Given this list of marker genes Kdm4b, Fibin, Tvp23b, Psg16, Pcdhgb2, Rc3h2, Otol1, Rnf152, Amn1, Tmem199, B3gnt5, Bicd1, Eif3a, Tox4 (NCBI Gene Id 98198), Fgf16, Spdl1, Lrig1, Brox, Gmfb, Lrrc7, Yeats2, Akap11, Zfx, Anp32e, Smim7, AI593442, Efnb2, Synj1, Il15ra (NCBI Gene Id 98822), Eea1, Zcchc24, Ttc7b, Arhgap11a, Mindy2, Rab3ip, Speg, Adcyap1, Thap1, Boc, Nek7, Mfsd1 (major facilitator superfamily domain containing 1), Map3k12, Zfp367, Pan3, Glrb, Atxn7, Pin1, Nlgn1, Zfp800, Tbp, Clca4a, Wnt9b, Tsc22d2, Thsd7b, Phyhipl, Kcnh8, Fam177a2, Nckap5, Sv2a, Il17a, Ewsr1, Dnd1, Csf3, Hsd17b7, Nr1h4, Zfp839, Bmp5, Tmem169, Serinc5, Pcgf3, Dnajc6, Cmtm4, Uba2, E2f1, Ncs1, Hectd2, Homez, Whrn, Cldn14, Gtf2e2, Dip2b, Cops2, Aqp5, Vezt, Kntc1, Casd1, Notch3, Neurod1, Zc3h15, Birc5, Hyou1, Zdhhc21, Cx3cl1, Asxl1, Lrch1, Fzd8, Rgs16, Dlat, Pcdhga6, Ppp3r1, Shox2, Ofd1, Itga6, Il12a, Jmy, Lysmd1, Map2k6, Hoxa3, Slc35a3, Lrfn4, Anln, Sema3a, Neurog2, Palld, Rnf111, Phf21a, Zc2hc1a, Ranbp9, Olfm3, Dusp8, Fam89a, Slc35d1, Atad2b, Map2k1 (NCBI Gene Id 26395), Srm, Lamc1, Selenoi, Celf4, Stk40, Tnfsf9, Med1, Prpf40b, Ptpdc1, Spry2, Rictor, Peli2, Ccbe1, Aldh1a3, Icam1, Med13, Galnt18, Cacna2d1, Pmaip1, Gng12, Adamts1, Dnaaf9, Actr10, Dpf3, Thbd, Ch25h, Mmaa, Cnot6l, Lrat, Cask, Adgrl4, Mier3, Foxp1, Tns3, Adamts19 (ADAM metallopeptidase with thrombospondin type 1 motif 19), Ccn1, Aff4, Cep120, Gpr158, Cdc42bpg, Cftr, Tubgcp5 (tubulin, gamma complex component 5), Carmil1, Ffar4, Pdik1l, Sycp2, Bicral, Pcdhga7, Daam1 (dishevelled associated activator of morphogenesis 1), Smurf2, Card19, Mafk, Arid5b, Clk3, Bdnf, N4bp2l1, Ppp3cc (protein phosphatase 3, catalytic subunit, gamma isoform, NCBI Gene Id 19057), Radil, Dock4, Nedd1, Tiam1, Katnal2, Btbd10, Trp53inp1, Fam91a1, Ddx3x, Tmem33, Btbd8, Uimc1, Retreg1, Dap3, Spryd7, Rgs20, Tet2, Brinp2 (NCBI Gene Id 240843), Limch1, Atxn2l, Ccdc82, Akap12, Sprr2a2, Wnt5a, Rab6a, Kcng3, Tyr, Stk3 (NCBI Gene Id 80435), Hif1a, Lin9, Irx2, Dpp4 (NCBI Gene Id 13482, dipeptidylpeptidase 4), Notch1, Abcg4, Mzt1, Il4, Gpatch2l, Nr1d1, Plk3, Zfp950, Baz1a, Amer3, Hoxd8, Ptchd4, Gng2, Tppp, Htr4, Cd274, Csgalnact2, Rala, Clcn3, Pif1, Zfp292, 1700066M21Rik, Hk2 (hexokinase 2), Gpc2, Myef2, Tfap2e, Elavl1, Lrrc39, Pcdh11x, Tmeff1, Dspp, Tmem132c, Baz2a, Dlg2, Stk26, Frk, Plk2, Cytip, Macroh2a2, Fa2h, Arl5a, Usp31, Dynll1, Pnisr, Prkce, Tesk2, Syt14, Lrrc71, Tmprss11g, Pcdhgc3 (protocadherin gamma subfamily C, 3), Baz1b, Slmap, Nphp3, Dmtf1, Chmp5, Inppl1, Twist2, Rbpj, Mmgt1, Id2, Fasn, Idh2, Lats1, Trpc1, Traf4, Tspan14, Onecut2, Bmp4, Bdp1, Golt1b (NCBI Gene Id 66964), Edn2, E130308A19Rik, Trak1, Shroom3, Nfxl1, Celsr2, Rgs17, Cep85, Ppfia2, Gad1, Dctn6, Pcdhga2, Hnrnpll, Kcnb2, Atosa, Elavl4, Nlrc5, Dock5, Trappc13, Kcnma1, Bloc1s4, Grpel2, Pof1b, Fat1, Odf2, Tmem68, Rora, D3Ertd751e, Lmtk2, Sass6, Myrip, Rap2c, Efs, Zic2, Cnot2, Jade1, Tmem161b, Hrh1, Tmem167, Irag1, Tnfrsf22, Epha7, Prss56, Mcur1, Eif4a2, Foxj3, Fam135a, St18, Zfp979, Pcdhgb8, Pcdh18, Samsn1, Col5a2, Nppb, Cadm2 (NCBI Gene Id 72986), Clasp1, Il1r1, Etnk1, Zfyve27 (NCBI Gene Id 72352), Scn1a, Zfp941, Rab3a (RAB3A, member RAS oncogene family), Dlg4, Ube2ql1, Zxdc, Macf1, Lrp6, Aftph, Csrnp2, B230219D22Rik, Ehbp1, Bbx, Tox3, Gdf15, Serpini1, Zxdb, Epc2, Mtm1, Robo2, Pknox2, Wdr47, St8sia2, Gm13889, Mmp16, Gfod1, Col8a1, Axin2, Cdk17, Tmco3, Tmem67, Skor1 (NCBI Gene Id 207667), Zcchc9, Csf2 (NCBI Gene Id 12981), Eif2ak3, Pecam1, St8sia5, Tusc3, Rasgrf2 (NCBI Gene Id 70739), Ube2w, Gfpt2, Bod1l, A830018L16Rik, Hps3, Atp6v1c1, Adamts4, Sntb2, Cdh9, Rnf182, Plat, Nr1d2, Zbtb24, Ebf1, Irak2, Arhgef9, Kif14, Emc1, Pip4p2, Wnt3, Cul5, Ciao1, Rph3al, Adgrb3, Eya3, Srpra, Rfx6, Matn3, Rab40c, Zfp365 (NCBI Gene Id 674611), Stard13 (NCBI Gene Id 243362), Asap1, Dda1, Ankrd44, Stambpl1, Dmd, Zfp758, Zfp667, Slc6a1, Wdr26, Pbrm1, Hcn3, Lrrk2, Ldlr, Phip, Zfp790, Phtf2, Tshz1, Slc4a7, Cyp7a1, Mfsd6, Tmem196, Kcna1, Csrnp1, Hhip, Taf3, Chrd, Lrsam1, Nr5a2, Abr, C1galt1, Ptar1, Kctd6, Asah2 (NCBI Gene Id 54447), Plekha1, Prdm6, Zfp236, Nr4a3, Gem, Lmo7, Fstl3, Hectd4, Nrn1l, Aldh1a2, Vegfa, Pcdha4b, Neurod4, Lcp2, Ccp110, Heatr5b, Slc16a12, Tti1, Igfbp3, Zfp503, Foxf1, Usp46, Gpr174 (G protein-coupled receptor 174), Pcnx1, Ppat (NCBI Gene Id 97242), Tsga10, Atxn7l3, Fzd1, Celsr1, Adamts6, Crhr1, Sin3b, Vps37a, Spring1, Map1a, Fign, Sh3glb1, Usp12 (ubiquitin specific peptidase 12), Ppm1h, Slc45a3, Baz2b, Cdyl2, Cxcl1, Zbtb10, Vbp1, 1810055G02Rik, Snai1, Myl12b (NCBI Gene Id 98057), Ntf3, Rnf225, Snrnp27, Tnfaip3, Prr12, Adamts9, Zc3h12c, Grk3, Cdk6, Sprr2a1, Hivep1, Adamtsl1, Fgf4, Wnt11, Glce, Ssxb10, Mast4, Arhgef26, Dnal4, Zfp609, Thsd7a, Ccl20, Phox2b, Tbc1d9, Agfg2, P2ry1, Ncoa7, Ngf, Gapvd1, Yae1d1, Pfkm, Brsk1, Dennd4b, Cfap69, Smarcad1, Plekhm3, Edn1, Rbm27 (RNA binding motif protein 27), Il22, Fpgt, Cflar, Serinc1, Nlrp3, Crim1, Gtf2a2, Pex13, App, Lin7a, Rnf214, Got1, Gsc, Zswim6, Psmc3ip, Rrm2b, Pgbd1, Lpl (NCBI Gene Id 16956), Rccd1, Stag1, Sytl4, B4galt6, Gba2, E2f2, Ntrk3, Ino80d, Usp15, Fam221a, Nup155, Map9, Rasef, Ttbk2, Atosb, Bcor, Angpt1, Adamts16 (NCBI Gene Id 328284), Zfp143, Pias2, Rif1, Six1, Elmod2, Ccar1, Fgf10, Ppp2r5e, Rwdd3, Pik3c2a, Pik3cb, Cd28, Lep, Drd1, Cdca4, Asb7, Pou3f1, Slc25a14, Pate2, Ark2n, Megf6, Tm9sf3, Klhl2, Bcl2, Il31, Agfg1, 2310057M21Rik, Unkl, Il5, Slc5a12, Ipcef1, Trim33, Epas1, Elavl3 (NCBI Gene Id 66572), Pcdhgb1, Chfr, Herc1, Ssr3, Lrp8, Rufy2, Tet3, Plxnb3, Sall3, Gpr65, Tfap2a, Bnip5, Rnf145, Cdh8, Nup188, Noa1, Gdnf, Gtf2a1, 4921524J17Rik, Cnst, Trp53bp2, Opa1, Slc16a10, Zfp804a, Tcf12, Tubgcp3, Cd200, Kcnc2, Mphosph6, Fgf9, Sinhcaf, Smad7, Atp6v1e1, Fosl2, Pigf, Edil3, Rbbp8, Nup160, Lyrm9, Camta1, Cdkl3, Fzd7, Spag9, Pgf, Orc1, Cux2, Clmn, Tnfrsf11b, Elavl2, Elovl3, Pi15, Gsx1, Csn2, Papola, Atp2a2, Gria4, Mbnl2, Chst11 (NCBI Gene Id 68647), Abhd10, Bhlhe23, Sgk3, Eif5, Rybp, Gabra2, Arf4, Micall1, Pcdhgc5, Capn7, Dek, Il13, Shisa3, Ahr, Trio, Smg8, Arhgef2, Prkch, Cpa4, Pfkfb2, Rnd3 (NCBI Gene Id 99050), Pla2g4e, Actmap, Adap1, Akap13, Cish, Usf3, Rims2 (NCBI Gene Id 72660), Efemp1, Arih1, Ptch2, Nhlh2, Slc25a22, Heca, Kdm2b, Znrf3, Klhl18, Rngtt, Rmnd5a, Mkrn3, Mef2a, Ssxb9, Nt5c3 (5'-nucleotidase, cytosolic III), Hoxc4, Il3, Spry4, Cers2, Vax1, Kiss1r, Foxq1, Trappc8, Zfp689, Bpnt2, Carf, Insc, Abi3bp, Ncapd3, Erp44, Ptprm, Golim4, Arhgap42, 5730507C01Rik, Fam228b, Jhy, Nfe2l2, Simc1, Epha4, Tbc1d23, Fam3c, Eif2b3, Myt1l, Trip4, Arhgef3, Pabpc5, Med12, Il21, Smim17, Rbms1, Myl12a, Unc80, Fndc3b (NCBI Gene Id 99920), Ambn, Sertad4, Fam204a, Naa15, AU015228, Gpr171, Fzd4, Sgo2a, Pcdhga9, Fut9, Zfp592, Nhlh1, Kif5b, Adamts20, Acsl4, Tmem88b, Lhx3, Mgat4c, Col9a1, Malt1, Fgr, Zmym2, Nbea, Rock2 (Rho-associated coiled-coil containing protein kinase 2), Efhd1, Ssbp2, Lin54, Rasgrp1, Zbtb26, Yju2b, Tbx5, Vasn, Tiparp, E2f8, Lipg, Cpeb3, Slc37a1, Tnfaip6, Tnfrsf10b, Ndufs4, Baalc, Cycs, Sstr1, Atrx, 1600014C10Rik, Gtf2f2, Stxbp1, Socs3, Rnf139, Nog, Hagh, Ptx3, Pdp1, Slit2, Six4, Mcc, Satb2, Macir, Rad17, Foxn4, Smad6, Pdzd8, Neurl1a, Ssxb2, Gnai1, Itgav, B3galnt2, Hoxb9, Reps2, Ankrd13d, Csmd3, Calm1 (calmodulin 1), Wnt9a, Mtfmt, Jazf1, Mfap3l (microfibrillar-associated protein 3-like), Plce1, Traf5, Mmp13, Zbed6, Dgkd, Nsun6, Ifnb1, Myt1 (NCBI Gene Id 18237), Ptp4a1 (NCBI Gene Id 98792), Mrpl41, Ccdc50, Foxn2, Hamp, Cntn3, Slc38a2, B3galt1, Dll3 (delta like canonical Notch ligand 3), Fos, Fgf21, Auh, Fancm, Prickle1, Col11a1, Fmr1, Tecrl, Skint7, Mrpl1, Cggbp1, Zfp516, Mblac2, Ror2, Rnf43, Bcr (NCBI Gene Id 71258), Ric1, Tmtc1, Zfp963, Mllt3, Dusp11, Neto1, Car8, Gpd2, Ficd, Cass4, Bmpr1b, Klf11, Ncor1, Tra2a, Skil, Slc2a3, Nufip2, Fgfrl1, Atp6v0c, Slc12a7, Pcdhga8, Ube3a, Efcab7, Fyttd1, Ifi213 (NCBI Gene Id 623121), Fam78b, Arl6ip6, Atg16l1, Cdkn2aipnl, Atp13a3, Cmas, Zfp329, Bmp7, Or7d10, Kcnh1 (NCBI Gene Id 16510), Tlcd4, Pdcl, Arpp19, Mtpn, Zfp830, Ppp2r5b (protein phosphatase 2, regulatory subunit B', beta), Hunk, Eloa, Pax9, Tmtc3, Tmem52b, Tulp3, Mesp1, Stk39, Nploc4, Atp10a, Mcfd2, Srprb, Dusp1, Suz12, Snip1 (NCBI Gene Id 76793), Ap4e1, Fzd3 (NCBI Gene Id 320969), Lrp12, Cbx4, Sft2d2, Cstf3, Rgma (repulsive guidance molecule family member A), Dlgap2, Ankrd12, Pcdhga12, Slc30a9, Tnf, Ermn, Actc1, Snapc3, Kcnk1, Tlcd3b, Osbpl8, Tinagl1, Micu3, Nabp1, Nr6a1, Inpp5a, Fgf15, Cdh10, Gm38666, Pde3b, Zfta, Osm, Ikzf2, Kctd9, Hapln1, Nxpe3, Gbx2, Jkamp, Prkaa2, Chac1, Yipf4, Tanc2, Lrig3, Hmgb2, Atg4d, Zeb1, Sorcs1, Cox17, Tmem185a, Nkd1, Tbx20, Hs6st1, Piezo1, Psd3, Zfp9, Ube2v2, Arhgap29, Col12a1, Gfpt1, Zbtb49, Dlc1, Nrarp, Ptk2, Camsap1, Mideas, Tshz3, Rp1, Bcl11a, Ccdc171, Trp53rkb, Slc35d3, Col2a1, Pcdh20, Doc2b, Cttnbp2nl, Mfsd14b, Arhgef10, Zfp11, Ubxn7, Myo10, Ostf1, Tceal1, Pcdhgb5, Tdrd3 (tudor domain containing 3), Wls, Paxbp1, Srebf1, Adam22, Tbc1d15, Grb10, Ndufv2, Rapgef4, Efr3b, Yod1, Syt4, Acvr1, Ddr2, Cobll1, Strbp, Arpp21, Stim1, Enc1, Cnot6, Pdxp, Akap6, Il11, Sox6, Dcaf12, Ptpn13, Cyld, Lrch4, Elk1, Cldnd1, Bcl7a, Lrrc4c, Lif, Spopl, Tlr3, Fgf20 (NCBI Gene Id 80857), Ark2c, Ssxb1, Pcdhgb4, Ikzf5, Scoc, Pdlim5, Hsf5, Rab18, Kmt5b, Arhgap6, Pcbp2, Lgi1, Clcf1, Zdhhc9, Mak16, Myo1b, Mapre3, Rbm24, Tmcc2, Peli1, Cldn23, Nadk2, Rarg, Pum2, Plau, Dner, Nufip1, Samd4, Clip4, Abcb1a, Cd300lf, Kansl1, Mindy3, Fzd5, Wnt7a, Cds2, Cpeb2, Bmpr2, Calcoco1, Ptf1a, Dennd5a, Max, Net1, Neto2, Mapk6, Strip2, Taok1, Rbm41, Pcdhga5, Ripk2, Tfap2b, Alg11, Cdc14a, Polr3d, Ing3, Ptgs2, Bmp2, Ppm1e, Twf1, Inpp5e, Tapt1, Spry1, Artn, Asap2, Golga4, Tpp2, Ppp4r2, Suco, Mpp2, Hoxc6, Med12l, Tfap2c (transcription factor AP-2, gamma), Ppp6r3, Gfi1, Bnip2, Eno2, Nup88, Tmc1, Xpo1, Tmem184b, Pcdhgb7, Cers4, Nrg3, Fgf23, Srf, Zeb2, Ulk2, Tomm20, Arl15, Tifa, Senp6, Ube2g2, Ercc6, Cirbp, Ppp2r1b, Fam234b, Slc19a3, Ralgds, Nkiras2, Zfp36l1, C1galt1c1 (C1GALT1-specific chaperone 1), Hbegf, Dscam, Syncrip, Btg3, Slc41a1, Crybg3, Tbc1d13, Tulp4, Tanc1, Brwd1, Creb1, Dgka, Dr1, Cd44, Nppc, Mmp12, Camsap2, Zfp92, Svil, Cemip, Nos2, Akain1, Rhot1, Tec, Tor4a, Pou3f4, Il23a, St3gal1, Gpr3, Pak5, Samd3, Duxbl1, Atn1, Hoxb3 (homeobox B3), Anks1b, Il2, Morc2a, Cttnbp2, Ubald1, Kdm4a, Zmynd19, Lamtor5, Srrm4 (NCBI Gene Id 78602), Prkaa1, Cip2a, Sdc2, Ccnt2, Cenpf, Colgalt2, Dusp18, Inpp4b, Tcf24, Homer1, Cdc40, Stam, Adgrg6, Rerg, Lrp5, Ifng, Fam177a, Lgalsl, Dvl1, Fst (NCBI Gene Id 99160, follistatin), Atp6v0b, Slc25a17, Ereg, Otud6b, Creb3, Cep152, Cript, Creb5, Ptprk, Hoxd3, Sema3d, Thbs2, Pcdhga11, Col10a1, Kif3c, Atp6v1h, Igfbp1, Edem1, Plppr5, Pdgfb, Ahcyl2, Pde4b, Chodl, Zfp174, Pitpnb, Robo1, Braf, Lacc1, Gabpb2 (NCBI Gene Id 99849), Arid1b, Plk5, Rassf3, Gpr22, Nsd3, Pnpla2, Tmtc2, Nfat5, Eaf1, Map1b, Hus1 (HUS1 checkpoint clamp component), Gask1a, Rc3h1, Dmpk, Dcun1d3, Bard1, Col3a1, Akirin2, Ppfia1, Mosmo, Ip6k3, Relt (RELT tumor necrosis factor receptor), Adipor2, Ppm1b, Csde1, Cxcl2, Klhl21, Faap24, Trim36, Madd (NCBI Gene Id 353087), R3hdm2, D930020B18Rik, Bcl11b, Zfp36l2, Fbrs, Gm5796, Mtmr12, Trak2, Igfbp2, Ero1b, Chsy3, Cd40lg, Il22b, Ankfy1, Elmo2, Insm1, Clasp2, Il10, Fbxl14, Mier2, Cd55, Pakap, Fmn1, Hdac9, Map4, Tmem64, Calb1, Maff, Bmper, Copg1, Pcdhga1, Ugcg, Jrkl, Tbc1d22b, Lnpk, Trappc10, Med13l, Shprh, Prrc2b, Sema6a, Rsbn1l, Hace1, Wwp1, Mllt11, Lurap1l, En2, Cdk5r1, Csrnp3 (cysteine-serine-rich nuclear protein 3), Metap2, Cdkn1b, Rad54l2, Slc24a2, Arl5b, Zfp382, Fgfr3, Csmd1, Dusp2, Adamtsl3, Rad51d, Zgrf1, Pyurf, Jag1, Lrrc57, Epha2, Prdm1, Atxn2, Akt3, Rlig1 (NCBI Gene Id 75940), Crebrf, Aqp4, Sucla2, Gpd1l, Nod2, Apbb2, Cpne3, Cep76, Zfp712, Ccser2 (coiled-coil serine rich 2), Arap2, Wwtr1, Pcdhgc4, Rbm47, Cyth2, Gsx2, Frs3, Tagln3, Peds1, Inpp4a, Mettl25b, Ell2, Sertad2, Cblb, Usp47, Slf1, Has1, Gfral, Sptbn1, Hmbox1, Nova1, Fam180a, Acbd5, Zic3 (NCBI Gene Id 22773), Chl1, Cdk2, Smim3, Fbn2, Apold1, Zbtb6, Pcdhga10, Dll4, Dipk2a, Coq10a, Cep128, Il20, Zbtb22 (NCBI Gene Id 81630), Wnt4, Serpinb2, Slc20a2, Fry, Dock7, Dgke, Sbno2, Phf20l1 (PHD finger protein 20-like 1), Adamts3, Dmwd (dystrophia myotonica-containing WD repeat motif), Ctdspl2, Fat4 (NCBI Gene Id 329628), Adgrg2, Phlda1, Galnt3, Itga8, Zc3h11a, Klhl29, Tnfaip8l3, Uncx, Pabir1, Isl1, Zswim4, Kdm7a, Mpzl3, Riok3, Erc2, Ebf3, Plcxd2, Gsk3b (glycogen synthase kinase 3 beta), Nanos1, Cnih3, Ezr, Rusc2, Ugt2b35, Plekhh2, Pld2, Arid2, Lin7c, Stip1, Ap1s2, Rb1, Trappc2, Magohb, Nfkbia, Ralgapa1, Tmem184a, Sost, Lancl1, Pcdhga3, Xpo7, Klf10, Atp1b1 (NCBI Gene Id 11931), Bcar3, Sypl1, Mthfd2l, Fam174a, Hmcn1, 9330159F19Rik, Fbxo46, Ddhd1, Tent4b, Ltn1 (listerin E3 ubiquitin protein ligase 1), Col19a1, Gch1, Fbxw7, Ptprz1, Il17f, Sun1, Il1a, Slc2a13, Cul2, Otx1, Adcy9, Samd4b, Dennd5b, Capn12, Dock8, Slc25a25, Asb6, Sim1, Kctd13, Plekha3, Proser2, Kdm4c, Kmt2c, Cdc73, Itpkc, Tcim, Hecw2, Ppp2r2d, Tmem185b, AW209491, Tab2, Rab12, Gria2, Eef2, Zfp36, Col25a1, Txnrd1, Zdhhc17, Adcy7, Pptc7, Cxadr, Chd6, Runx1, Smad3, Lpp, Tmprss11f, Cd40, Rasgrp3, Myo1e, Tamalin, Tcp1, Gcnt2, Styk1, Fgf7, Noct, Dscaml1, Arhgap19, Ankrd40, Hoxb2, C2cd2l, Itfg1, Slc1a2, Khdc4, Utrn, Kdm6a, Plxdc2, Fermt1, Cyfip2, Il6, Antxr2, Gtf3c1, Elovl4, Dhps, Polr3a, Lta, Slc8a1, Spred1, Twist1, Tmed7, St6galnac5, Unc5c, Mastl, Ntrk2, Cbx3, Mybl1, Wsb1, Eef1e1, Wt1, Ccno, Itgb2, Slc15a1, Sema3f, Cep97, Ankrd1, Slc12a4, Parm1, Pkd2, Il10ra, Trpv4, Satb1, Prss22, Far1, Slc6a15, Nedd4, Itk, Plcl1, Dtwd2, Pik3cd, Hoxb5, Mctp2 (NCBI Gene Id 244049), Il1b, Or8d4, Aco2, Lcorl, Hoxa5, Tasor2, Stx16, F3, Appl2, Nid2, Pcolce2, Slc25a26, Atp2b4, Polk, Dlg3, Pmpcb, Znrf1, Syde2, Fam76b, Oaf, Manea, Serpinb10, Sp4, Ier3, Pkd1, Lats2, Ip6k2, Mttp, Kpna3, Epha3, Jph1, Tiprl, Pcdhga4, Fgd6, Cep170, Cfl2, Mbtps1 (membrane-bound transcription factor peptidase, site 1), Asph, Pcdhgb6, Pkn2, Smcr8, Swap70, Cacnb4, Kcnh5, Zfp235, Nyap1 (neuronal tyrosine-phosphorylated phosphoinositide 3-kinase adaptor 1), Mapkbp1, Strn3, Cdc45, Arnt, Dlgap1, Cdon, Kbtbd8, Wapl, Sirt1, Pak2, Psme3, Tmx4, Tmc7, here is a description of the gene set: Mouse Gene Set: MIR_466L_3P from publication Chen Y, Wang X (PMID 31504780) species: Mus musculus Genes predicted to be targets of miRBase v22 microRNA mmu_miR_466l_3p in miRDB v6.0 with MirTarget v4 prediction scores > 80 (high confidence targets).